The following is a description of a gene set: studied in species Homo sapiens Human Gene Set: GOBP_THORAX_AND_ANTERIOR_ABDOMEN_DETERMINATION Specification of the central (trunk) regions of the embryo by the gap genes; exemplified in insects by the actions of the Kruppel gene product., and this is the list of marker genes: WT1, NEUROG1, TIFAB, DCANP1, BASP1